Given this list of marker genes Fgf2, Smo, Foxf1, Elf5, Hoxa5, Zfp703, Prlr, Lbh, Lats1, Irf6 (NCBI Gene Id 98477), Erbb4, Zfas1, Id2, Pinc, Ptch1, Foxb1, Cebpb, Hif1a, here is a description of the gene set: Mouse Gene Set: GOBP_MAMMARY_GLAND_EPITHELIAL_CELL_DIFFERENTIATION The process in which a relatively unspecialized epithelial cell becomes a more specialized epithelial cell of the mammary gland. studied in species Mus musculus